Given this list of marker genes CHGA, PKD2, F2 (NCBI Gene Id 14061), GRP, NRXN1, RGS2, INPP5A, GPR27 (G protein-coupled receptor 27), BICD1, here is a description of the gene set: Human Gene Set: GOBP_REGULATION_OF_PHOSPHOLIPASE_C_ACTIVATING_G_PROTEIN_COUPLED_RECEPTOR_SIGNALING_PATHWAY Any process that modulates the frequency, rate or extent of phospholipase C-activating G protein-coupled receptor signaling pathway. species: Homo sapiens